The following is a description of a gene set: studied in species Homo sapiens Human Gene Set: GOBP_NEURON_MATURATION A developmental process, independent of morphogenetic (shape) change, that is required for a neuron to attain its fully functional state., and this is the list of marker genes: AGRN (agrin), GATA2, B4GALT6, NR4A2, NTN4, ADGRB3, KCNIP2, NGF, APP, SMIM45, IRX5, SRRM4, CNTNAP2, MECP2, C1QL1 (complement C1q like 1), SPTBN4, LGI4, MTCH1, SCLT1, EPHA8, RAC3, KCNB1, RET, ACTL6B, C3, B4GALT5, BCL2, SCARF1, KCNQ3, CCDC39, SPG21, GLDN, LRRK2, RND1, RAC1, FEV, RB1, NRCAM, MYOC, CLN5, FBXO41, BCL11A, ANKS1A, CX3CL1, TBX6, KDM1A, CNTN2, C1QA, PICK1, MAP3K13, CDKN1C, VSX1, EDNRB, FARP2, EDNRA